The following is a description of a gene set: species: Mus musculus Genes positively differentially expressed in cell type: pDC (plasmacytoid dendritic cell) upon treatment with cytokine: FLT3L in mouse lymph nodes in vivo. Cytokines mediate cell-cell communication in the immune system and represent important therapeutic targets. A myriad of studies have highlighted their central role in immune function, yet we lack a global view of the cellular responses of each immune cell type to each cytokine. To address this gap, the authors created the Immune Dictionary, a compendium of single-cell transcriptomic profiles of more than 17 immune cell types in response to each of 86 cytokines (>1,400 cytokine-cell type combinations) in mouse lymph nodes in vivo. A cytokine-centric view of the dictionary revealed that most cytokines induce highly cell-type-specific responses. For example, the inflammatory cytokine interleukin-1β induces distinct gene programmes in almost every cell type. A cell-type-centric view of the dictionary identified more than 66 cytokine-driven cellular polarization states across immune cell types, including previously uncharacterized states such as an interleukin-18-induced polyfunctional natural killer cell state. from publication Cui A, Huang T, Li S, Ma A, Pérez JL, Sander C, Keskin DB, Wu CJ, Fraenkel E, Hacohen N (PMID 38057668) Mouse Gene Set: CUI_PDC_FLT3L_RESPONSE_UP, and this is the list of marker genes: H2-Ab1, Dhx29, H2-Aa, Cfl1, Actg1 (NCBI Gene Id 230535), Fcrla, Chchd2, Havcr1, Kti12, Wdfy4, Cfp, Lcp1, Hspa8, H2-Q4, Ly6d, Ppia, Pfn1, Ccnd1, Hsp90b1, Dusp6, Cd72